Given this list of marker genes UBE2F, LRRC51, JOSD1, TNFSF10, DISC1, PHYHIPL, C3AR1, PCDHB5, PLEKHF2, ASAP2, GPR135, BRI3BP, PLEKHS1, RPA3, MIS18BP1, PPP1R3A, KRTAP4-6, KALRN, CFL1, MTMR4, ZNF236, C5orf15, GRAMD1B, ZC3H12B, ATP1B4 (ATPase Na+/K+ transporting family member beta 4), CTCF, PFKFB1, TRMT10C, SLMAP, TAPBPL, FAM162B, RBMS3, SPRED3, DTX4, CTBP2, GRPEL1, FAM117B, MAK16, HAPLN1, CCNB3, KIF26B, SEPTIN11, GOPC, AFF1, HMBOX1, ZNF578, CHD2, RASSF3, MOSMO (NCBI Gene Id 730593), RBM39, RPS6KB1 (ribosomal protein S6 kinase B1), RGS21, MRPL42, SLC34A2, PRRX1, TAOK1, C5orf24, VCP, ZFYVE28, TMEM174, JADE3, APOL3, PMP22, POLR1C, NCALD, ELMO1, KIAA0930, here is a description of the gene set: Genes predicted to be targets of miRBase v22 microRNA hsa-miR-6740-5p in miRDB v6.0 with MirTarget v4 prediction scores > 80 (high confidence targets). from publication Chen Y, Wang X (PMID 31504780) studied in species Homo sapiens Human Gene Set: MIR6740_5P